Given this list of marker genes Prc1, Kif14, Rhoc, Rhob, Dlg4, Rhoa (NCBI Gene Id 51787), Rac1, here is a description of the gene set: species: Mus musculus RHO GTPases activate CIT Mouse Gene Set: REACTOME_RHO_GTPASES_ACTIVATE_CIT